The following is a description of a gene set: Mouse Gene Set: GOMF_PROTEIN_KINASE_A_CATALYTIC_SUBUNIT_BINDING Binding to one or both of the catalytic subunits of protein kinase A. species: Mus musculus, and this is the list of marker genes: Smo, Prkar2a (protein kinase, cAMP dependent regulatory, type II alpha), Rab13, Sox9, Ezr, Ryr2, Pja2, Prkar2b, Gsk3a, Csk, Kcnq1, Akap11, Pkia, Gsk3b (NCBI Gene Id 98033), Prkar1a, Prkar1b